The following is a description of a gene set: This event has been computationally inferred from an event that has been demonstrated in another species.<p>The inference is based on the homology mapping from PANTHER. Briefly, reactions for which all involved PhysicalEntities (in input, output and catalyst) have a mapped orthologue/paralogue (for complexes at least 75% of components must have a mapping) are inferred to the other species. part of: Signaling by NTRK1 (TRKA) electronically inferred by orthology from the curated human pathway Reactome Pathway: Signalling to ERKs species: Mus musculus, and this is the list of marker genes: Frs2, Kidins220, Shc2 (SHC (Src homology 2 domain containing) transforming protein 2), Hras, Shc3, Mapk3, Mapk11, Ralgds, Ngf, Shc1, Mapk14, Grb2, Map2k1, Crk, Map2k2